The following is a description of a gene set: species: Homo sapiens Marker genes curated from the annotated cluster as represented in the Descartes Human Gene Expression During Development database. Human Gene Set: DESCARTES_FETAL_MUSCLE_VASCULAR_ENDOTHELIAL_CELLS from publication Cao J, O'Day DR, Pliner HA, Kingsley PD, Deng M, Daza RM, Zager MA, Aldinger KA, Blecher-Gonen R, Zhang F, Spielmann M, Palis J, Doherty D, Steemers FJ, Glass IA, Trapnell C, Shendure J (PMID 33184181) The gene expression program underlying the specification of human cell types is of fundamental interest. The study authors generated human cell atlases of gene expression and chromatin accessibility in fetal tissues. For gene expression, the study authors applied three-level combinatorial indexing to >110 samples representing 15 organs, ultimately profiling ~4 million single cells. The study authors leveraged the literature and other atlases to identify and annotate hundreds of cell types and subtypes, both within and across tissues. Our analyses focused on organ-specific specializations of broadly distributed cell types (such as blood, endothelial, and epithelial), sites of fetal erythropoiesis (which notably included the adrenal gland), and integration with mouse developmental atlases (such as conserved specification of blood cells). These data represent a rich resource for the exploration of in vivo human gene expression in diverse tissues and cell types., and this is the list of marker genes: PTPRR, KITLG (NCBI Gene Id 780897), SOX17, NOSTRIN, EFCAB14, MADCAM1, PRR29, FAM124B, TMEM88, RAB3C, IL33, RBP7, VEGFC, ANO2, CCM2L, NOTCH4, GRIA2, NOX4, INMT, TM4SF1, CD300LG, TMEM150C, CLIC5, ACKR1, FLT1, TMEM255B, LIMASI, GRIN2A, NOS2, TAFA2, F2RL2, TMC1, ENSG00000253348, CYYR1, LY86-AS1, RAMP3, NOS3, PLVAP, SLC5A4, C1orf115, GRASLND, RAPGEF5, APLN, C1QTNF9, GFRAL, ADGRL4, LINC01697, LIPE, ESM1, ENSG00000233251, NRN1, ADAMTS18 (ADAM metallopeptidase with thrombospondin type 1 motif 18), EGLN1, CYYR1-AS1, PRCP, SOX7, CD93, EYS, AVPR2, MAPK11, CA4, LINC01362, FAM167B, LINC01695, C2CD4B, SELE, TPO, DLL4 (delta like canonical Notch ligand 4), BTNL9, PTPRM, PRSS51, PRND, MMRN2, TM4SF18-AS1, SLC9C1, ENSG00000233461, SPNS2